The following is a description of a gene set: studied in species Mus musculus from publication Yevshin I, Sharipov R, Kolmykov S, Kondrakhin Y, Kolpakov F (PMID 30445619) Mouse Gene Set: SMCHD1_TARGET_GENES Genes containing one or more binding sites for (Smchd1) in their promoter regions (TSS -1000,+100 bp) as identified by GTRD version 20.06 ChIP-seq harmonization., and this is the list of marker genes: Bad, Gm26590, 5330439K02Rik, Irx3os, Bzw1, Pofut2 (protein O-fucosyltransferase 2), Gm10941, Clint1, Glra1, Sik3, Wasf2, Gpr137, Ptpn13, Ube2g2, Rc3h2, Herc3, Arhgap31, Xpo7, Luc7l3, Supt5, Nap1l1, Dagla (NCBI Gene Id 269060), Pcdh7, Rnase4, Slc39a13, Gas2, Hnrnpk, Nudt3, Vps13b, Crlf2, Ube2o, Plekhg1, Septin7, Gabarap, Thnsl1, Hnrnpa2b1, Opn1sw, Ddx42, Zscan25, Ctnna3, Enkur, Gm27042, Atn1, Bicdl1, Gin1, Ywhaz, Aldh18a1, Mrpl1, Pnkd, Banp, Mapt, Rnf2, Cacng3, Usp30, Mir7-1, Gm7964, Ddx17, Supt16, Ak1, Stx16 (NCBI Gene Id 99409), Eif4g2, Tia1, Polrmt, Rfc5, Pin1, Ang, Cnpy2, Mynn, Letmd1, Gm11205, Tpgs1, Cpne4, Slc25a25, Nap1l5, Ccdc47, Gm27011, Inpp5f, Cuedc1, Smchd1, Cops7a, Gm15728, 2610005L07Rik, Adgrb3, Lamp1 (NCBI Gene Id 234071), Gm15722, Cbx3